Given this list of marker genes DHX15, MACF1, RNF111, FAAP20, ID4, here is a description of the gene set: Genes having at least one occurence of the motif GTCGATC in their 3' untranslated region. The motif represents putative target (that is, seed match) of human mature miRNA hsa-miR-369-5p (v7.1 miRBase). studied in species Homo sapiens Human Gene Set: GTCGATC_MIR3695P